The following is a description of a gene set: studied in species Mus musculus Mouse Gene Set: GOMF_PORE_FORMING_ACTIVITY An activity in which a protein is inserted into the membrane of another cell where it forms transmembrane pores. Pores disrupts the integrity of the cell membrane, resulting in deregulated ion homeostasis, cellular dysfunction, and can result in cell death., and this is the list of marker genes: Defa40, Defa32, Defa28, Defa25, Defa27, Defa17, Defa20, Defa37, Mpeg1, Defa30, Defa26, Defa31, AY761185, Defa34, Defa3, Defa36, Defa2, Defa5, Prf1, Defa41, Defa35, Mmd2, Defa23, Mmd, Defa24